Given this list of marker genes IFT70A, ERG, PPARGC1A, PARD3, RBMS3, GREB1, ARHGAP26, SLC41A1, SOX14, UBR1, EFNB2, LAPTM4A, ZNF561, AKAP6, INPP5J, CNRIP1, OCRL, KBTBD8, TRHDE (NCBI Gene Id 29953), PRG4, STRBP, CAPS (calcyphosine), LEF1, MFNG, DAZAP1, BICRAL, FAM199X, CHRNA3 (cholinergic receptor nicotinic alpha 3 subunit), TBXT, ZNF704, RASSF3, COL9A1, IL5RA (NCBI Gene Id 3568), SOX6, TSPAN2, ETV5, GXYLT1, DNAL1, ELOVL7, LSAMP, MRTFA, MIER3, CERT1, FBXO30 (F-box protein 30), UBE2Z, RBM24, ABCB10, SLC16A7, CXXC4, SH3D19, FBXO42, HAS3 (NCBI Gene Id 3038), PPDPFL, PDGFRA, GRAMD1B, SLC35E1, ATG14, EYA1, RPRD2, SYT5, MMS19, PDE4D, ZNF697, ANAPC10, ASH1L, MBNL1, TNRC18, AKAP13, RAB35, DDAH1, SKIDA1, CAMK1D, FURIN, KCNH8, PIGR, DNAJC6, DOK6, ZC3H6, PIGG, ADCYAP1, ABRAXAS1 (NCBI Gene Id 84142), RIMS1, BTBD7, ADGRE2, ANKRD44, SLC31A1, TPCN1 (NCBI Gene Id 56236), DCAF10, PRDM16, TENM2, LGALSL, SLC39A10, WEE1, KIAA1549, CC2D1A, SLC46A3, SDK1, ROR1, SNRK, SLC12A8, DCBLD2, SLK, CDYL2, ANKRD52, NR2C2, TGFBR2, IL12B, SEMA4G, CD164, SSBP2, CGNL1, S100PBP, CXXC5, MECOM, FBXO3, TSC22D2, UBASH3B, UBE3A, CLOCK, ZEB2, THRB, ELMOD2, PRKAA2, THSD7B, TMX4, PCDH17, RECK, CCNA2, ZBTB18, SCAI, CLASP1, FHIP1B, LPP, CCDC28A, ARMC8, ISL1, FAM210B, EYA2 (EYA transcriptional coactivator and phosphatase 2), DIAPH3, TMEM98, LURAP1L, KCNA4, ABHD13, CDH1, CHD7, FOXJ3, STK38L, CRLF3, MEF2D, here is a description of the gene set: studied in species Homo sapiens Genes predicted to be targets of miRBase v22 microRNA hsa-miR-6766-3p in miRDB v6.0 with MirTarget v4 prediction scores > 80 (high confidence targets). from publication Chen Y, Wang X (PMID 31504780) Human Gene Set: MIR6766_3P